The following is a description of a gene set: from publication Yevshin I, Sharipov R, Kolmykov S, Kondrakhin Y, Kolpakov F (PMID 30445619) Genes containing one or more binding sites for (ZNF837) in their promoter regions (TSS -1000,+100 bp) as identified by GTRD version 20.06 ChIP-seq harmonization. Human Gene Set: ZNF837_TARGET_GENES studied in species Homo sapiens, and this is the list of marker genes: TOB2, YAP1, DANCR, ANO8 (anoctamin 8), MIR4449, EXOSC6, GTPBP3, CALM1, SNORA26